The following is a description of a gene set: BMP15 signaling pathway. Pathway ID: N01455. Pathway type: Reference. Pathway class: nt06507 TGFB signaling. Human Gene Set: KEGG_MEDICUS_REFERENCE_BMP15_SIGNALING_PATHWAY Pathway Definition from KEGG: BMP15 -> (BMPR2+BMPR1B) -> (SMAD1,SMAD5,SMAD9) == SMAD4 species: Homo sapiens, and this is the list of marker genes: SMAD5, SMAD9, SMAD4, BMPR1B, SMAD1 (SMAD family member 1), BMPR2, BMP15